The following is a description of a gene set: studied in species Homo sapiens Human Gene Set: GOBP_RIBOFLAVIN_TRANSPORT The directed movement of riboflavin into, out of or within a cell, or between cells, by means of some agent such as a transporter or pore. Riboflavin (vitamin B2) is a water-soluble B-complex vitamin, converted in the cell to FMN and FAD, cofactors required for the function of flavoproteins., and this is the list of marker genes: RTBDN, SLC52A1, SLC52A3, SLC52A2, SLC22A14, ABCG2